The following is a description of a gene set: Genes up-regulated in RSV (A549 cells, MOI: 2, 24hpi) Analysis of the transcriptional response to SARS-CoV-2 compared with other respiratory viruses, including MERS-CoV, SARS-CoV-1 (SARS), human parainfluenza virus 3 (HPIV3), respiratory syncytial virus (RSV), and IAV. from publication Blanco-Melo D, Nilsson-Payant BE, Liu WC, Uhl S, Hoagland D, Møller R, Jordan TX, Oishi K, Panis M, Sachs D, Wang TT, Schwartz RE, Lim JK, Albrecht RA, tenOever BR (PMID 32416070) species: Homo sapiens Human Gene Set: BLANCO_MELO_RESPIRATORY_SYNCYTIAL_VIRUS_INFECTION_A594_CELLS_UP, and this is the list of marker genes: ADM2, CSF3, SAMD9L, LAMP3, BMAL2, HSPB8, NFKBIZ, IFNL1, LMO2 (LIM domain only 2), IDO1, IL20RB, SEMA3D, TAP1, ICAM4, BST2, TNIP3, SP100, CHST2, NID2, OAS3, MMP9, PTPRH, P4HA1 (prolyl 4-hydroxylase subunit alpha 1), GALNT12, PLEKHA4, DHX58, TCAF2, GBP1, HAS3, TNFSF14, HELZ2, C3, CXCL2, BMP2, HERC6, BIK, B3GNT5, IL21R, CFB, FSTL1, PTX3, PPP1R15A, RUNX2, ANPEP (alanyl aminopeptidase, membrane), ZMIZ1-AS1, CHST11, STC1, ZBTB32, USP18, SAMD4A, TNFSF10, APOL2, NIPAL1, IFI44L, GCKR, DSEL, CPM, LDLR, NKX3-1, LACC1, GFPT2, NIBAN1, TNFAIP3, UCA1, LY6K, CXCL11, GPAT3, STX11, ERAP2, IFIT3, IL4R, CD55, CXCL1 (C-X-C motif chemokine ligand 1), IRF7, GK, SERPINB8, BIRC3, FBXO32, MXD1, SPOCD1, APOL1, IL12A, CORO2B, SERPING1, IFNB1, ADGRE2, SDC4 (syndecan 4), C15orf48, XDH, CCL2, IL7R, KLF4, TNFRSF9, ST3GAL1, STAT2, IGFN1, AMPD3, STRIP2, IFNL2, DDX60, MX2, COL15A1, PMAIP1, CD274, WARS1, HSPA6, MMP10, TNFRSF10A, TNFSF13B, IFI16, CLMP, IL6, PARP10, CRYBG1, IL15RA, OAS1, HCAR3, CEACAM1, PLOD2, IRAK2, RET, IFI44, MMP1, CREB5, CA13, TMEM158, EMP1, CDH3, APOL3, TNFRSF1B, IRF1 (NCBI Gene Id 96501), ITGA5, SP140L, TNC, IFIH1, TRANK1, PARP14, C6orf58 (chromosome 6 open reading frame 58), OSMR, HBEGF, TFPI2, TMEM140, STAT1, CMPK2, ULBP2, CRTAC1, CH25H, KCNQ3, SELPLG, XAF1 (XIAP associated factor 1), ETS1, SORBS1, CRISPLD2, TMEM154, SOD2, LCP1, TRAF1, CCL4, IFIT2, ATF3, CDCP1 (CUB domain containing protein 1), CCBE1, SBSN, IFIT1, KRT17, RSAD2, HIVEP3, FAM43A, ARG2, PARP12, CD68, TGM2, ABCA1, ICAM1, UBA7 (NCBI Gene Id 7875), HSPA1B, KDM7A, DDX60L, THEMIS2, ADAM19, STC2, MX1 (NCBI Gene Id 4599), ZNF697, ID4, TRIM22, PLAU, GBP3, LEISA1, ZC3HAV1, ENTPD7, MYH16, PTGER4, COL13A1, P4HA2, NT5E, CXCL10, IL1RAP, ITGB3, HRH1, CD82, POU2F2, MICB, LAMC2, IL1A, RAET1L, TMCC3 (NCBI Gene Id 57458), LAMA4, SPOCK1, RFPL2, PTPRE, CXCL8, PPM1K, SAA2, SAMHD1, SAMD9, MAFF, ZNFX1 (zinc finger NFX1-type containing 1), DTX3L, OASL, SERPINE2, EGR1, SOCS3, NFE2L3, MCTP1, SLC6A12, ALOXE3, NRIP3, KIAA1217, ZC3H12A, CSF1, NAV3, NLRC5, GIPR, MAP2, HK2, LAP3, BCL2A1, ANTXR2, VDR, GBP5, GBP2, KLK10, HERC5, IL1B, F3, RAET1E, HCAR2, COL17A1, PGF, RIGI, IFITM1, SH2B3, PLAUR, DCLK1, PARP9, GBP4, BATF2, LIPG, GLIPR1, PITPNC1, ACHE, FOXQ1, CDK5R2, CASP1, TNF, CTSS, SLC6A15, SLFN5, C1S, RASGRP3, IFNL3, EFNB2, IGFBP1, SORCS2, MREG, NCF2, RGS2, SP110 (SP110 nuclear body protein), UBE2L6, CCL3, APOL6, AOX1, PTAFR, B2M, TLR3